The following is a description of a gene set: studied in species Homo sapiens Human Gene Set: MIR6513_5P Genes predicted to be targets of miRBase v22 microRNA hsa-miR-6513-5p in miRDB v6.0 with MirTarget v4 prediction scores > 80 (high confidence targets). from publication Chen Y, Wang X (PMID 31504780), and this is the list of marker genes: HEY2, HDAC9, CCDC14, ALG14, DPY19L1, GPBP1L1, AMER3, FARP2, MAP6, CUX1 (NCBI Gene Id 1523), TNRC6C, EPGN, RPL15 (ribosomal protein L15), H2AZ1 (H2A.Z variant histone 1), POU2F1, BPNT2, MTF1, RHAG, PPTC7, YPEL2, SLC25A32, NEBL, GOLGA4, PLEKHS1, TSTD2, FAM114A1, MOB1A, HOOK3, GPAM, VSNL1, TMEM212, CORO1C, ALDH6A1, SF1, ITPR2, RNF169 (ring finger protein 169), KLF7, CLOCK, PCDHB5, GPC6, TLR8, UBR5, RBM18, PRTG, ZSWIM9, KIAA0930, PDK3, RPS6KB1, GABRB3, KLRG1, CBLN2, RALGPS2, PLN (phospholamban), FAM20A, CLIP3, DESI2, ADGRG4, ANKRD17, LSM1, MKX, FBXO33, CADM3, RBMXL2, IL1RAP, MIDEAS, STC1, MATN3, SFRP5, CBX2, KCTD4, HSP90B1, ZNF326, SLC19A4P, RNF24, ILDR2, C6orf136, KRT5, TRERF1, ATP1B4, FOXP1, RINL, CHTOP, CTNNB1, CDNF, PTPN2, IL2, DLAT, WBP1L, HAPLN1, MLH3, NSD1, PHF8, C19orf84, TAOK1, GPR158, LUZP1, TMEM178B, SPRYD7, SCML2